The following is a description of a gene set: from publication Chen Y, Wang X (PMID 31504780) species: Homo sapiens Genes predicted to be targets of miRBase v22 microRNA hsa-miR-1284 in miRDB v6.0 with MirTarget v4 prediction scores > 80 (high confidence targets). Human Gene Set: MIR1284, and this is the list of marker genes: KLF6, LSM14A, THAP12, GOSR1, MAST4, BCL11B, UBE2D1, ZC3H12B, ECT2, HMGB1, HIVEP1, SDC2, CCDC182, CSPP1, CDH6, IRS1, FAM76B, CREBBP, RXRG, MAB21L2, GAS1, NREP, UBL3, ASB11, PRR23A, USP24, CAPZA2, PPP2R5C, NCAM1, SPRY4, TMED7, RAB33A, SORBS1, PHLPP1, SMARCB1, KMT2E, ADRB2, RFK, NFASC, TASOR (NCBI Gene Id 51687), RNF34, MAK, POLR2K, DOP1A, EIF4ENIF1, NELFA, ZNF436, RBM47, PDE1C, FBXO33, DENND4A, TES, MGA, TFCP2L1, TPD52, MRS2, ANK1, CARMIL1, SNAI2, MARK1, MPZL2, CFAP95, STOX2, ZCCHC18, SRSF10, ITGB2, SVIL, ZNF236, LDLR, RBM41, KRAS, RNF214, KALRN, RORA, UBR5, MCM9, PPP4R2 (NCBI Gene Id 56340), MED14, PDS5B, REV3L, PSD3, SKIL, MARCHF6, FKBP1A, MEST, CD8A, IFI44L, RTF1, ZNF281, WBP4, LIN9, SP100, PHACTR4, RNF2, SELENOK, ZNF652, EP300, SF3B1, FRMD4B, PIAS1, SNX31, MARK3, SUMO1, ARHGEF12, DCUN1D4, SNAI1, AKAP10, SEC24D, OSGIN2, ATP2A2, PACRG, HOXA13, RAB10, KLHL4, PAPOLG, ATAD5, NLK, RB1CC1, MRPL44, BROX, GMNC, SLITRK3, SCAF8, CPSF2, SEC22A (SEC22 homolog A, vesicle trafficking protein), FNDC3B, IREB2, RIF1, INO80D, DCAF7, GIN1, MDC1, NRXN1, ETV5, ZNF697, PPM1K, SP8, PPP2R2C, TRIP12, DCLRE1B, EIF4A1, TAOK3, LDLRAD4, DNPEP, TADA1, JAK2, CD55, RAD51B, GLG1, CARMIL3, FYTTD1, PIK3C2A, MAP1B, LRRC1, TMEM260, BDNF, IRF2BPL, TFB1M, ERBIN, TEDDM1 (transmembrane epididymal protein 1), AUTS2, HMGB2, SGIP1, ZBTB2, HACE1, TSHZ3, POM121L12 (POM121 transmembrane nucleoporin like 12), PCGF5, NUP153, DHRS7, HCFC2, ZFPM2, WDR48, PDLIM1, UBQLN1, ID4, TSC22D2, RBM27, ADGRF5, TRIM2 (tripartite motif containing 2), GABRA1, REST, GSE1, DOCK3, SON, MTFR1, KIF13A, BCL9, JUP (junction plakoglobin), SULT1E1, CAMTA1, LBR, EPB41L2, SLC39A10, ATXN1, TAOK1, KCNE4, CUL1, RCN2, ZNF432, DSN1, DAGLA, SMARCE1, TNS3, ARL4C, ZNF384, CPEB2, RREB1, MEF2C, RRM2, C6orf136, UTY, SLC2A1, PRDM12, ACSL3, PEX14, CTTNBP2NL, IL12B, PTPN14, DLG2, USF3, KDM7A, TAB2, ID2, RNASE7, FMR1, NOTCH3, TOR1AIP2, KAT8, SMOC1, STXBP6, SLC19A2, SIPA1L2, ST6GALNAC3 (NCBI Gene Id 256435)